The following is a description of a gene set: species: Homo sapiens Human Gene Set: chr10q24, and this is the list of marker genes: ENSG00000286683, LINC02681, LCOR, HIF1AN, TPM4P1, LOXL4, MIR146B, C10orf95-AS1 (C10orf95 antisense RNA 1), ACTR1A, ENSG00000273162, OGA, PGAM1, MRPL43, DNTT (NCBI Gene Id 1791), PFN1P11, NKX2-3, TWNK (NCBI Gene Id 60508), LBX1, ZFYVE27, FBXL15, FGF8, FRAT1, BLNK, TRIM8, SH3PXD2A-AS1, ERLIN1, HPS6, RNU6-1231P, PYROXD2 (NCBI Gene Id 84795), SH3PXD2A, SUFU, PSD, ARHGAP19, TLL2, KCNIP2-AS1, KAZALD1, PPRC1, CUTC, SLIT1-AS1, ZNF518A, CYP17A1, GOT1-DT, CUEDC2, MIR1307, RPL23AP58, MARCKSL1P1, SLC25A28, NT5C2, NPM1P26, RNU6-43P, ENSG00000286575, CALHM1, PTGES3P4, ARHGAP19-SLIT1, PI4K2A, GOLGA7B, NDUFB8, PCGF6, CYP2C23P, WBP1L, SEC31B, PITX3, ENSG00000289745, ENTPD7, ANKRD2, BTRC, MIR3158-2, AVPI1, R3HCC1L, ATP5MK, HMGN2P35, LDB1, FBXW4, MFSD13A, MARVELD1, MIR1287, TAF5, LBX1-AS1, RPS3AP36, ARL5AP2, SCD (NCBI Gene Id 6319), STN1, NANOGP6, SLIT1 (NCBI Gene Id 6585), AS3MT, TRIM8-DT, RNU6-422P, C10orf62, CALHM2, OPALIN, RNU11-3P, GOT1, ENSG00000289441, DNMBP, RPS15AP29, ABCC2, ZDHHC16, COX15, RNA5SP324, ENTPD1, CNNM1, OLMALINC, INA, MIR3158-1, CPN1, CCNJ, MMS19, RPL34P20, HPS1-AS1, RPL13AP5, LINC01514, SMARCE1P7, NFKB2, FRAT2, MIR4685, ELOVL3, DNMBP-AS1 (DNMBP antisense RNA 1), PDCD11, C10orf95, CHUK-DT, LINC01475, PKD2L1, RPS2P36, SPCS2P2, PIK3AP1, NEURL1-AS1, POLL, RNU6-1274P, LINC03046, TLX1, BORCS7, CNNM2, SLK (STE20 like kinase), GBF1, SFXN2, PDZD7, NPM3, BORCS7-ASMT, PAX2, TLX1NB, KCNIP2 (potassium voltage-gated channel interacting protein 2), RNU2-59P, CRTAC1, MIR607, MIR6507 (NCBI Gene Id 102465253), DPCD, WNT8B, TM9SF3, GOLGA7B-DT, ALDH18A1, UBTD1, SLC25A28-DT, CWF19L1, SNORA12, CHUK, RPL22P17, NEURL1, CC2D2B, MIR3157, RPEL1, RRP12, TCTN3, RNU2-43P, CALHM3, EBAG9P1, HPSE2, NOLC1, RN7SL524P, SFXN3, HPS1, RNU6-1165P, MIR608, ST13P13, EXOSC1, SFRP5, RPL12P27, SORBS1, ARL3, HOGA1, ARMH3, RPL7P36, PHB1P9, RNU6-271P, RPL21P90, ENTPD1-AS1, NPM1P25, LZTS2, MORN4, SLF2, SEMA4G, BLOC1S2